The following is a description of a gene set: Hypertrophic cardiomyopathy with an asymmetrical pattern of hypertrophy, with a predilection for the interventricular septum and myocyte disarray. Asymmetric septal hypertrophy studied in species Homo sapiens Human Gene Set: HP_ASYMMETRIC_SEPTAL_HYPERTROPHY, and this is the list of marker genes: CAV3, MYLK2, SGSH, KLHL24, MYH7, PRKAG2, MYOZ2, HGSNAT, FHOD3, NAGLU, GNS, MYH6, MYL2